The following is a description of a gene set: Genes down-regulated in thymocytes: double positive versus CD8 single positive. Human Gene Set: GSE22601_DOUBLE_POSITIVE_VS_CD8_SINGLE_POSITIVE_THYMOCYTE_DN T cells develop from progenitors that migrate from the bone marrow into the thymus. Thymocytes are subdivided roughly as being double negative (DN), double positive (DP), or single positive (SP), based on the expression of the CD4 and CD8 coreceptors. The DN stage is heterogeneous and can be subdivided into four distinct subsets in mice based on the expression of CD44 and CD25. In human, three distinct DN stages can be recognized: a CD34+CD38−CD1a− stage that represents the most immature thymic subset and the consecutive CD34+CD38+CD1a− and CD34+CD38+CD1a+ stages. Human DN thymocytes mature via an immature single positive (ISP CD4+) and a DP stage into CD4+ or CD8+ SP T cells that express functional T cell receptors (TCR) and that exit the thymus. In this study, gene expression was measured in each of these nine stages. studied in species Homo sapiens from publication Dik WA, Pike-Overzet K, Weerkamp F, de Ridder D, de Haas EF, Baert MR, van der Spek P, Koster EE, Reinders MJ, van Dongen JJ, Langerak AW, Staal FJ (PMID 15928199), and this is the list of marker genes: MED9, PPP1R10, CIT, EHMT2, P2RX7, LHPP, TINF2, MAPKAPK2, GEM, MSH6, LMNA, APEX1, KDM1A, CRLS1, TREX1, TPX2, UMPS, MTHFD1L, PLIN2, TRIM59, PAFAH1B3, BORA, SCPEP1, BLOC1S2, CCDC18, TBC1D31, FKBP5, BRIP1, ARHGEF39, AGL, DCAF4, POGLUT2, CASP7, LDHB, HNRNPR (NCBI Gene Id 10236), TBC1D7, VEZF1, PCK2, NAT10, DSN1, MICAL1, GYPC, AKAP7, PSMC6, PYCR3, GOLIM4, TENT2, SRBD1, MRPS35, GPR68, LGALS1, UNC93B1, BANK1, SESTD1, NIBAN1, AAK1, CEMIP2, PRELID3B, CCT4, TCERG1, PQBP1, IDH2, JMJD1C, UBR7, TMEM192, DCTPP1, RPTOR, GSTCD, EPB41L2, MLLT3, H2AZ1, YIF1A, NCAPD2, DNASE1L1, LSM2, PDLIM4, AAAS, CD83, GJA1, MZT1, FUCA1, LRRC75A, SLF2, EEF1G, RFWD3, DECR1, UGP2, KIF11, CRIP1, HAUS4, ADPRM, PEX16, SP1, SMS, ERI1, RPUSD1, SRPK1, ADAMTS6 (ADAM metallopeptidase with thrombospondin type 1 motif 6), TNFAIP8L1, ZFP1, ILF3 (interleukin enhancer binding factor 3), XBP1, TOP3A, TRMT2B, ZBTB22, CENPA, CDIN1, GRK5, PWP1, TTC8, TFB1M, SAE1, NFIL3, SDHAF3, NPM1, DAP, RALBP1, ICAM1, MPHOSPH9 (NCBI Gene Id 64797), ZFP28, CDC6, BMI1, MLF1 (myeloid leukemia factor 1), SERPINF1, CDK4, ISOC1, HAUS3, CHEK2, KDM2B, TDP2, RTN3, ZMYM1, DTNBP1, NUDT1, PLK4, USP22, NDFIP1, TNFSF4, DDIAS, NGLY1, MTMR3, AP1G2, PIERCE1, BTBD19, RAN, AARSD1, CDK2AP1, NANP (N-acetylneuraminic acid phosphatase), TACC3, ANAPC7, C8orf76, WASHC1, SPDL1, C12orf75, HLA-DQA1, PRKCD, TMEM263, ENTPD1, RCC2, C11orf54, PTER, GAS2, CEP57, CCNE2, CEP72, MGST3, CDC45, SLC25A1, LRRCC1, MFSD11, ASF1B, ILVBL, KMT5C, AJUBA, NEIL3, CCDC90B, SIN3B, CENPC, KPNA2, TBX21, BRCA1, DNPEP, CCDC77, PHLDA1, C7orf50, DHFR, BEND5, RCC1, CD28, STK35, FH, IRAK1BP1 (interleukin 1 receptor associated kinase 1 binding protein 1), CSRP2, BATF3 (basic leucine zipper ATF-like transcription factor 3), POLR2H, PFAS (NCBI Gene Id 5198), CHD1L (chromodomain helicase DNA binding protein 1 like), CHCHD5, ALDOA, AP3S2